Given this list of marker genes Tbp, Polr2k, Gtf2h2, Polr1e, Ercc2 (excision repair cross-complementing rodent repair deficiency, complementation group 2), Mta1, Polr1g, Polr2f, Gtf2h4, Ccnh, Taf1d, Rbbp4, Ercc3, Polr1c, Polr2e, Ercc6, Polr2l, Mbd3, Polr1h, Mapk3, Rbbp7, Mta2, here is a description of the gene set: species: Mus musculus Reactome Pathway: RNA Polymerase I Transcription electronically inferred by orthology from the curated human pathway part of: Gene expression (Transcription) This event has been computationally inferred from an event that has been demonstrated in another species.<p>The inference is based on the homology mapping from PANTHER. Briefly, reactions for which all involved PhysicalEntities (in input, output and catalyst) have a mapped orthologue/paralogue (for complexes at least 75% of components must have a mapping) are inferred to the other species.